Given this list of marker genes ASPRV1, KLF7, NEK7, KY, ADCK1, BICC1, STX3, CDKN1A, FUT8, NID1, FHL3, MORN3, TC2N, UBTD1, ADAMTS1, CAVIN4, BAALC, FAM133B, IL4R, DTX1, CDK8, HIC1, UBL3, SLC5A2, METRNL, RUVBL2, PVALB, PIWIL2 (piwi like RNA-mediated gene silencing 2), ARMCX1, RAD52, AOC1, SERPINE1, C6orf120, RYR3, C1QTNF12, EAF2, KL, SOX6, MFAP5, MDM2, IL13RA1, TOMM70, RHBDF1, ADAM15 (ADAM metallopeptidase domain 15), TRAF4, OSR1, CREB3L2, CSTA (cystatin A), TLX2, ALPL (alkaline phosphatase, biomineralization associated), MAFG, HECTD1, TMOD2, MYH2, PRRC1, ELMO1, LBX1, PPP1R42, KCND2, CAMKK1, SPOUT1, CFTR, RIOK3, SAV1, ALDH1A3, AADAC, ARL4A, WNK1 (WNK lysine deficient protein kinase 1), TMEM123, EIF4E3, ENPP2, ESPN, PIM1, TGM1, CCDC115, ANGPT1, EEF1A2, PTGER3, PPFIBP2, SEMA5B, ACBD3, CNTN1, ZFP37, TCTN2, FBN1, ABCG5, ALG14 (ALG14 UDP-N-acetylglucosaminyltransferase subunit), BCR, CDH8, KLC1, C3orf70, ST7, MYCBPAP, FOXD2, IL22, CRCT1, GALR1, CER1, PYY, CITED4 (Cbp/p300 interacting transactivator with Glu/Asp rich carboxy-terminal domain 4), JAM3, ZNF296, KMO (kynurenine 3-monooxygenase), PHKG1, PTH, KCND1, BTK, LUZP1, RNF5, FZD4, TRMT10C, PON1, TEX12, ZNF330, CRELD1, ZRSR2, HK2, MAPKAPK2, ACE, SNHG11, PAXBP1, IL1R1, IGLL1, CANX, SCARB1, MLPH, PPP3CC, TMEFF1, WARS1 (NCBI Gene Id 7453), HIC2, SLC2A5, ADH7, TEX2, RNF41 (NCBI Gene Id 93069), NR6A1, ACVRL1, C1S, MT4, GCM2, MCFD2, EPB41L4A, OVOL2, LRRC26, DES, CCNA1, GJD2, PTGFRN, LHB, NDST1, CKB, MTMR3, ABL1, FOXL1, KLF9, P2RX4, CD82, MFHAS1, ALLC (allantoicase), CSGALNACT1, GPR146, KSR1, ZFP91, ATP6V1B1, LAMA5, HYAL3, NOCT, ECM1, CACNA1D, KRT20, AGPAT5, GNAT1, NBN, KIF5B, MIA2, IPO4, PDE3A, HBEGF, CAPN10, TAL1, GCNT2, PDZRN3, NDRG2, SART3, TGM2, FGF9, TMPRSS5, CFAP95, CA4, CSNK2A1, SLTM, CYP4F3, ECRG4, PCDHB11, GRID2IP, RRAS2, SPECC1, GJC1, HERPUD1, ADRB3, RDH13, here is a description of the gene set: species: Homo sapiens CD8+ T cells play a crucial role in the clearance of intracellular pathogens through the generation of cytotoxic effector cells that eliminate infected cells and long-lived memory cells that provide enhanced protection against reinfection. We have previously shown that the inhibitor of E protein transcription factors, Id2, is necessary for accumulation of effector and memory CD8+ T cells during infection. Here we show that CD8+ T cells lacking Id2 did not generate a robust terminally-differentiated KLRG1hi effector population, but displayed a cell-surface phenotype and cytokine profile consistent with memory precursors, raising the question as to whether loss of Id2 impairs the differentiation and/or survival of effector-memory cells. We found that deletion of Bim rescued Id2-deficient CD8+ cell survival during infection. However, the dramatic reduction in KLRG1hi cells caused by loss of Id2 remained in the absence of Bim, such that Id2/Bim double-deficient cells form an exclusively KLRG1loCD127hi memory precursor population. Thus we describe a role for Id2 in both the survival and differentation of normal CD8+ effector and memory populations. from publication Knell J, Best JA, Lind NA, Yang E, D'Cruz LM, Goldrath AW (PMID 23325888) Human Gene Set: GSE41978_KLRG1_HIGH_VS_LOW_EFFECTOR_CD8_TCELL_UP Genes up-regulated in CD8 T effector cells during infection: KLRG1 high versus KLRG1 low.